Given this list of marker genes DUSP2, TNIP1, MICAL2, MAPK14, NBR1, DUSP16, SIRT1, PPM1D, MAPKAPK5, DUSP10, DIRAS1, ABL1, PRMT1, PRKG2, CDK5RAP3, NFATC1, DUSP1, STAU2 (staufen double-stranded RNA binding protein 2), TAB1, ATF7, TPR, MAPKAPK3, PRKG1, ACE (angiotensin I converting enzyme), PTPRJ, MAPKAPK2, GCH1, MAPK7, here is a description of the gene set: Binding to a mitogen-activated protein kinase. Human Gene Set: GOMF_MITOGEN_ACTIVATED_PROTEIN_KINASE_BINDING species: Homo sapiens